Given this list of marker genes BRCA2, NRAS, H19, GPC3, AKT1, CDKN1C, KCNQ1OT1, POU6F2, IGF2, HRAS, DNMT3A, PIK3CA, AKT2, ACTB, KRAS, DIS3L2, ZNF699 (NCBI Gene Id 374879), TRIP13, REST, HNF1B, RNF125, KCNQ1, TRIM28, WT1, RASA1, here is a description of the gene set: Human Gene Set: HP_HEMIHYPERTROPHY Overgrowth of only one side of the body. studied in species Homo sapiens Hemihypertrophy